The following is a description of a gene set: The process in which individual somites establish identity during embryogenesis. studied in species Homo sapiens Human Gene Set: GOBP_SOMITE_SPECIFICATION, and this is the list of marker genes: COBL, MEOX1, RIPPLY1, DLL1, MEOX2